Given this list of marker genes APOH, APOA5, FAF2, APOB, GPIHBP1, LRPAP1, CLPS, PLIN5, ANGPTL4, ANGPTL3, here is a description of the gene set: species: Homo sapiens Binding to a lipase. Human Gene Set: GOMF_LIPASE_BINDING